Given this list of marker genes IGF2R, UROD, IRF5, MSH6, IL12A, TCF4, ABCB11, POLD1 (DNA polymerase delta 1, catalytic subunit), GPR35, BRCA2, TP53, CASP8 (caspase 8), PMS1, POU2AF1, MMEL1, CHEK2, IGF2, HFE (NCBI Gene Id 3077), ABCB4, FAS, SEMA4A, PDGFRL, EPCAM, G6PC1, TULP3, BMP2, SLC37A4, RPS20, BTK, KRAS, FASLG, POLE, JAK2, AHCY, JAG1, SLC2A2, SLC25A13, PMS2, MLH1, MPV17, CASP10, TGFBR2, MET, MUTYH, SPRTN, TJP2, APC, SERPINA1, PHKB, SEMA4D, FAH, AXIN1, HBB, F5, PPOX, GIMAP5, ASL, PIK3CA, MST1, HMBS, PYGL, BMP6, MSH2, SPIB, BMPR1A, TNFSF15, ATP7B, CTNNB1, ATM, PRKAR1A, CPOX, TNPO3, IL12RB1, PDE11A, here is a description of the gene set: Hepatocellular carcinoma A kind of neoplasm of the liver that originates in hepatocytes and presents macroscopically as a soft and hemorrhagic tan mass in the liver. species: Homo sapiens Human Gene Set: HP_HEPATOCELLULAR_CARCINOMA